The following is a description of a gene set: Mouse Gene Set: MIR_5617_5P studied in species Mus musculus from publication Chen Y, Wang X (PMID 31504780) Genes predicted to be targets of miRBase v22 microRNA mmu_miR_5617_5p in miRDB v6.0 with MirTarget v4 prediction scores > 80 (high confidence targets)., and this is the list of marker genes: Atxn7, Skida1, Snapc4, Cthrc1, Akap11, Edem2, Ssbp2, Bcl7a, Frem2, Arid4b, Thsd7a, Rubcn, Ift70b, Plxnc1, Btbd6, Adamts12, H2-Ob, Clip3, Sp3, Ndufaf4, Gab2, Vdac1, Prdm1, Mylk, Szrd1, Tor1aip2, Neurod6, Pitpnm3, Kctd8, Abcc5, Arid2, Pgap1, Plppr5, Mstn, Orc4, Esp18, Gpr158, Mapk1ip1l, Arhgap29, Dnajb9, Rab2a, Gm14461, Esp16, Esp15, Slc8a1, Rsf1 (NCBI Gene Id 77334), Neurl4, Marveld3, Znrf3, Sgo2a, Kbtbd2, Sdcbp, Cryz, Ccr3, Acsm2, Tfec, Gnb1, Myrf, Snx2, Lsamp, Neil3, Cnst (NCBI Gene Id 226744), Cr2, Calu, Clasp2, Als2, Prkag2 (NCBI Gene Id 73700), Cntln, Baalc, Hecw2, Pggt1b, Tnfaip8l3, Pias3, Nipa1, Rala, Sucnr1, Slc6a14, Itgb4, Fzd4, Atp11c, Caprin2, Prex2, Pkn2, Igf1, Prl7c1, Cnksr2, Vezf1, Jakmip1, Slc35b3, Gabra4, Slc2a13, Fzd6, Tmem229a, Cep57, Cnot6l, Zfp113, Casz1